Given this list of marker genes Aldh9a1, here is a description of the gene set: electronically inferred by orthology from the curated human pathway This event has been computationally inferred from an event that has been demonstrated in another species.<p>The inference is based on the homology mapping from PANTHER. Briefly, reactions for which all involved PhysicalEntities (in input, output and catalyst) have a mapped orthologue/paralogue (for complexes at least 75% of components must have a mapping) are inferred to the other species. studied in species Mus musculus part of: Metabolism of amino acids and derivatives Reactome Pathway: Carnitine synthesis